Given this list of marker genes UBE2E1, PSMC4, CDC27, PSMC5, UBE2C, BUB3, CDC20, ANAPC1, PSMD14, ANAPC10, CDK1, ANAPC16, PSMD1, CCNA1, CDC16, ANAPC7, PSMD3, PSMA1 (NCBI Gene Id 5682), PSMA6, UBC, PSMD7, PSMC6, PSMB6, BUB1B, ANAPC4, PSMB2, PSMB5, PSMB3, CDC26, UBB, PSMD12, PSMA3, RPS27A, CDC23, PSMB4, ANAPC2, PSMC1, MAD2L1, UBA52, PSMD2, PSMA7, PSMD6, PSMC2, CCNA2, PSMA5, PSMD8, ANAPC5, PSMA4, PSMC3, ADRM1, PSMB1, PSMB7, PSMA2, UBE2D1, SEM1, PSMD13, UBE2S, PSMD11, ANAPC15, ANAPC11, here is a description of the gene set: part of: APC:Cdc20 mediated degradation of cell cycle proteins prior to satisfation of the cell cycle checkpoint Cyclin A, functions in mitosis as well as DNA replication and is degraded in the interim by the APC/C to permit normal chromosome segregation, cell division, and the onset of S phase (see Lukas and Bartek, 2004). Cyclin A is initially degraded early in mitosis by APC/C:Cdc20 when the spindle checkpoint is still active and degradation of securin and cyclin B is inhibited. studied in species Homo sapiens Reactome Pathway: Cdc20:Phospho-APC/C mediated degradation of Cyclin A